The following is a description of a gene set: Human Gene Set: MIR410_3P from publication Chen Y, Wang X (PMID 31504780) Genes predicted to be targets of miRBase v22 microRNA hsa-miR-410-3p in miRDB v6.0 with MirTarget v4 prediction scores > 80 (high confidence targets). species: Homo sapiens, and this is the list of marker genes: COL4A3, CADM2, NHLH2, LPCAT2, CNOT7, CREBZF, RAPGEF2, ABHD18, SCAMP5, TAFA2, PSME4, LHX8, WNT5B, KAT6A, SPDYA, ATP8B2, C9orf72, PRKAA1, HIVEP1, ZNF644, OTX2, KLHL9, EAF1, TRPC1, RORA, DUSP2, RFX3, ADM, PTPRB, ZER1 (zyg-11 related cell cycle regulator), ZFX, KIAA0825, FCHO2, MAP3K12, TRIM23, TAS2R14, SEC23A, MATN3, ATG16L1, RPS6KA3, KIRREL1, PRPF18, ARHGAP29, COBLL1, CBFB, CFAP20, TNFSF11, LPCAT4, ST8SIA4 (ST8 alpha-N-acetyl-neuraminide alpha-2,8-sialyltransferase 4), ZCCHC10, GUCA1B, KLF6, PIK3IP1, HMGB1, CPNE8, GUCY1A2, RGMB, CLCA2, TRUB1, RAPGEF6, MOXD1 (NCBI Gene Id 26002), KLF10, SMAD7, RNF38, TENT5A, PBRM1, DNAL4, MGP, ZZZ3, PCNX1, DGKE, ASB15, MICU3, DGKH, UGGT2, SPDYE3, RAB30 (NCBI Gene Id 27314), OCLN, RIMOC1, ELMOD2, TPR, ATF1, ITPKB, ATAD5, VEGFA, PPP6R1, DNAL1, MANBA, SLC7A11, DISC1, ATN1, RPS24, TSHZ2, SNX3, MN1, MED13, CLEC6A, LETM2, OSBPL3, TIAM1, AVPR1A, PDZD2, KCNMB2, ERO1A, NUMB, SLC38A11, ROCK2, ETS1, GRIA2, MCFD2, TBX4, TMEM161B, GOLPH3, ZNF273, ADCYAP1, SVIL, PARD6G, MOB1B, FHIP1A (FHF complex subunit HOOK interacting protein 1A), TPTE2, CCNDBP1, SPDYE5, PRPF40A, GLRB, PRG4, TAT, MCM10, ZNF518B, IRAK1BP1, RNF6, PCDH8, VPS13C, ZNF492, TMEM106B, VGLL3, ARID5B, SP1, ETV6 (NCBI Gene Id 4348), PLPP3, RC3H2, STXBP5 (NCBI Gene Id 134957), MYH9, ZBTB34, SMARCA1, HACE1, FBXO34, SGPP1, ZNF548, NDFIP2, TDRD15, CREB5, GDF9, PCSK5, TEX14, B3GLCT, TMEM108 (transmembrane protein 108), COL15A1, CNOT6L, PTK2, G2E3, SDHD, EXOC6, ATRX, CDK19, CNTN4, EPB41L4B, NRDE2, ABHD10, CYP19A1, CACNB4, MKLN1, HTATIP2, TTYH3, AHCTF1, NDNF, ZNF274, SNTG1, AFF4, PGM2L1, FGF12, TNPO1, RTN4, OR2L13, LCOR, SPRED1, ATAD2, USP15 (NCBI Gene Id 9958), PDE4B, CCSER1, CHD1, CBX3, DCTN6, RUFY2, PSIP1, MED12, BMPR1A, SLC24A2, RUFY3, LIN7A, PREX2, ATP6V1H, PRDM11, SCEL, VCF1, NAMPT, NETO1, CCDC82, GRHL3, CXCR4, IPO7 (NCBI Gene Id 10527), SLC38A4, LNPK, RC3H1, SRSF2 (NCBI Gene Id 6427), PPFIBP1, MAGI3, PALS2, ASZ1, NCAM2, LIN9, TMTC1, KDM6A, CPEB4, SLC9A7, LRRC7, ZSWIM6, LCORL, SLK, SRSF11, ARID2, CFAP97, ANKRD29 (ankyrin repeat domain 29), ZNF585A (zinc finger protein 585A), MAGEB18, KDM7A, NAA15, GFPT1, SLC35G2, IWS1, SP3, TMEFF2 (transmembrane protein with EGF like and two follistatin like domains 2), ARMC10 (armadillo repeat containing 10), GPATCH2L (NCBI Gene Id 82392), STARD13, BAZ2B, PRRX1, TEC, ARMC8, NR3C1, CXCL5 (C-X-C motif chemokine ligand 5), STAG1, TMEM236, UTRN, UFM1 (NCBI Gene Id 51569), C21orf91, MAFG, SMPX, GPR180, GLS, C11orf87, FMR1, GLIS3, CPSF6, GIGYF2, TMED4, ELAVL4, FAM200B, SETD3, ACADSB, TBX5, ARHGAP5, FGF2, TENT4A, DPYSL2, NPPC, MSI2, LNX2, CPEB3, RERE, USP29, EXOC5, RP2, FBXL17, ZFY, VEPH1, PPP1R2, MFAP5, MMS22L, CEP152, RAD23B, BMPR2, ASB11, ERBIN (erbb2 interacting protein, NCBI Gene Id 55914), CHML, GAD1, CSNK1G3, SPDYE6, IL12A, DIO2, MAB21L1, RIDA, GSK3B, GLRA3, EYS, BTG3, PPP3CB, DLG3, CGNL1, SLC34A2 (solute carrier family 34 member 2), ZBTB41, TMEM170B, ZBTB44, KIAA0408, CNTLN, REST, MOSMO, PLXNA2, HTR2A, KDM4C, UBR3, FZD3, RFK, WNT3, SLC35C2, LMTK2, RAB11FIP2, SMAD6, POGLUT3, ACVR1C, SPDYE1, LSAMP, MANEA, RAB38